The following is a description of a gene set: studied in species Homo sapiens Genes down-regulated in nuocytes: control versus treated with IL7 and IL33. Human Gene Set: GSE25890_CTRL_VS_IL33_IL7_TREATED_NUOCYTES_DN Nuocytes are a recently described cell that responds to both IL-25 and IL-33 and produce high levels of IL-13 and IL-5 from publication Neill DR, Wong SH, Bellosi A, Flynn RJ, Daly M, Langford TK, Bucks C, Kane CM, Fallon PG, Pannell R, Jolin HE, McKenzie AN (PMID 20200518), and this is the list of marker genes: COG3, BLVRB, MYB, AK2, LETM1, URB1, HERPUD2, ANKRD52, CWC25, JARID2, TATDN2, TACC3, PHKG2, ACO2, RBM18, GEMIN6, RORA, YTHDC2, AKNA, ACTR8, UBTD2, RNGTT, FEN1, MARVELD2, PDIK1L, PAG1, NBN, SSR3, ZMAT1, PRNP, GPATCH8, NDUFAF4, RNF167, PLK3, P2RY10, SKIC8 (NCBI Gene Id 80349), C6orf62, TSFM, SYAP1, DAXX, TMEM248, RAMP3, RBM4B, SEPSECS, PER1, TAF4B, CASP6, LEO1, DNAJC12, STX12, TTC32, ARPC1A, TNFAIP1, LRRC8C, XIAP, AMN, CDC5L, PPP2R1B, VPS37A, CD300A, E2F5, HNRNPDL, RIMOC1, GTF3C6, RASA2, GCLM, QTRT2, DCAF10, NUAK2, KREMEN1, ZFP62, GID8, LAS1L, LIN9, ZNF655, ACSL5, ESYT2, MESD, FPGT, ERCC6, CLEC4A, AHNAK, RPS25, ANKH, ARHGAP25, TMEM70, CPEB4, PHF1, TTLL4, STRADB, PCM1, AAR2, BTBD9, OSBPL8, IGF2R, TNIP2, WEE2, HIPK1, RPS6KA3, NUP133, CLEC6A, CACUL1, RBM7, HLA-DMB, MRPL46, COMMD8, GPR137B, RAB5C, LAX1, BAHD1, NDUFS4, HLA-DOA, RRP9, ANXA3, MTFR1, ESR1, GXYLT1, ZRANB1, DDI2, DNAJB11, DDX19B, AGPAT2, CDR2, ROCK2, PSMC5, ORC4, UBE2E1, LAMP1, MBP, TXNDC5, STAR, TSEN54, WEE1 (NCBI Gene Id 7465), SATB1, KIF18A, TFAM, TTLL11, RINT1, DPH3, RPS27L, HNRNPUL2, NAP1L4, THUMPD3, PSIP1, KIDINS220, NOB1, IL1RAP, FAM177A1, GPR107, ETAA1, AGFG1, TUSC2, DDX46, SUCLG1, CCP110, TGFB1, MTAP, BCL2L13, STK38, LIPT2, ZEB2, FUS, CA2, ZZZ3, CENPJ, PHF20 (PHD finger protein 20), UBAP1, GPATCH4, ZC3H7A, PPFIA1, MRPL1, PAIP1, BCL7B, CCNL2, HNRNPH2, PNN, SLC25A3 (solute carrier family 25 member 3), TUBGCP4, MRPS18B, TMEM183A, BMAL1, ORMDL2, SAP30, STAM2, CSRP1, YY1, RMND5B, ARFGEF1, SIRT1, ATF7IP, ACBD3, UFM1, GINS4, EPC1, CNOT2, EGFL6, HSPA1B, ABRACL, TRAPPC8, COX18